Given this list of marker genes SCAF4, JMJD1C, RTL1, IFT56, DIS3L2, EP300, ZMYM3, PIK3R2, GDF1, SUCLG1, DLK1, CREBBP, CRELD1, MAP3K7, WT1, GNB2, NKX2-5, SMG9, GJA1, DNAH1, CIROP, DNAH9, STRA6, KDM6A, PPP2R1A, HIRA, ZIC3, IPO8, SEC24C, CLXN, KMT2D (NCBI Gene Id 8085), RREB1, MMP21, CFAP53, MCTP2, PUF60, MEG3, ARVCF, PPP1CB, FOXF1, FLT4, BCOR, DGCR8, GP1BB, DGCR6, COMT, MYRF, TBX1, DGCR2, GLI3, NKX2-6, SEMA3E, TELO2, GATA6, CHD7, UFD1, SF3B2, MYCN, ALG3 (ALG3 alpha-1,3- mannosyltransferase), PLXND1, GBA1, PIGN, ESS2 (ess-2 splicing factor homolog), KRAS, ACVR2B, PTH1R, TMEM260, PKD1L1, TBCK, WDR26 (NCBI Gene Id 80232), FGFR1, PLD1, here is a description of the gene set: Human Gene Set: HP_ABNORMAL_AORTIC_ARCH_MORPHOLOGY Abnormal aortic arch morphology An anomaly of the arch of aorta. species: Homo sapiens